Given this list of marker genes SYNE4, TCF15, RAP2A, MSN, TTC8, LAMA1, FOXF1, EZR, NHERF1 (NHERF family PDZ scaffold protein 1), OPHN1, MYO9A, RHOA, CAMSAP3, FAT1, IFT20, WNT5A, SH3BP1, CDC42 (cell division cycle 42), PTK7, here is a description of the gene set: The specification and formation of the apicobasal polarity of an epithelial cell. Human Gene Set: GOBP_ESTABLISHMENT_OF_EPITHELIAL_CELL_APICAL_BASAL_POLARITY studied in species Homo sapiens